Given this list of marker genes Ift27, Gdnf, Spry1, Gli3, Foxc1, Bmp4, Ift25, Slit2, Sall1, Ret, Gfra1, Robo2, Pax2 (paired box 2), Agtr2, Sox11, Sox17, Gata3, Foxc2, Lhx1, Fat4, Ctnnb1, Eya1, here is a description of the gene set: studied in species Mus musculus GDNF/RET signaling axis Mouse Gene Set: WP_GDNFRET_SIGNALING_AXIS